The following is a description of a gene set: Any process that modulates the frequency, rate or extent of synaptic vesicle exocytosis. species: Mus musculus Mouse Gene Set: GOBP_REGULATION_OF_SYNAPTIC_VESICLE_EXOCYTOSIS, and this is the list of marker genes: Fmr1, Slc4a8, Syt1, Cask, Stxbp5l, Ncs1, Pfn2, Sv2b, Fbxo45, Cspg5, Rab3gap1, Snapin, Git2, Kcnh1, Htr1d, Tprg1l, Syn1, Syt5, Bcl2l1, Htr1b, Cacnb4, Nlgn1 (NCBI Gene Id 99949), Npy1r, Snap29, Syt8, Rims1, Git1 (NCBI Gene Id 63992), Rims4, Dtnbp1, Wnt7a, Gpr151, Atp2a2, Prkcb, P2ry1, P2ry2, Vps18, Braf, Cacna1d, Syt13, Dnm1l, Dvl1, Rab3a, Prepl, Ppfia2, Rims2, Cacna1e, P2rx2, Stxbp5, Rims3, Lrrk2, Unc13b (unc-13 homolog B), Fbxl20, Rab5a, Syt4, Npy (NCBI Gene Id 68398), P2ry4, P2rx7, Prkcg, Syt2, Rap1a, Prkca, Rap1b (NCBI Gene Id 72733, RAS related protein 1b), Sv2c, P2rx1